The following is a description of a gene set: studied in species Mus musculus Reactome Pathway: Elevation of cytosolic Ca2+ levels electronically inferred by orthology from the curated human pathway part of: Platelet calcium homeostasis This event has been computationally inferred from an event that has been demonstrated in another species.<p>The inference is based on the homology mapping from PANTHER. Briefly, reactions for which all involved PhysicalEntities (in input, output and catalyst) have a mapped orthologue/paralogue (for complexes at least 75% of components must have a mapping) are inferred to the other species., and this is the list of marker genes: P2rx5, Trpc6, Trpc7, P2rx6, P2rx2, P2rx7